The following is a description of a gene set: Mouse Gene Set: GOMF_SUGAR_TRANSMEMBRANE_TRANSPORTER_ACTIVITY studied in species Mus musculus Enables the transfer of a sugar from one side of a membrane to the other. A sugar is any member of a class of sweet, water-soluble, crystallizable carbohydrates, which are the monosaccharides and smaller oligosaccharides., and this is the list of marker genes: Slc2a2 (NCBI Gene Id 99576), Mfsd4b5, Slc23a2, Slc2a7, Slc5a10, Slc2a6, Slc5a11, Slc5a4b, Slc45a1, Slc5a9, Slc2a10, Slc2a3, Slc2a12, Slc23a1, Slc5a3, Gm5134, Slc2a1, Slc2a9, Slc45a2, Slc2a5, Slc2a8, Slc5a1, Slc5a2, Slc5a4a, Slc2a4, Slc50a1